The following is a description of a gene set: The series of successive proteolytic cleavages of the Notch protein, which result in an active form of the receptor. Human Gene Set: GOBP_NOTCH_RECEPTOR_PROCESSING studied in species Homo sapiens, and this is the list of marker genes: NCSTN, PSENEN, PSEN1, DNER, PSEN2, APH1B, APH1A, ADAM17, GALNT11